The following is a description of a gene set: Mouse Gene Set: REACTOME_G_PROTEIN_ACTIVATION G-protein activation species: Mus musculus, and this is the list of marker genes: Pomc, Gng2, Gng5, Gnb5, Pdyn, Gna14, Gng10, Gng4, Gng13, Gna15, Gnb4, Gngt2, Gnb2, Gng12, Oprm1, Gng11, Gng3, Gng8, Gngt1, Gng7, Gnaq, Gna11, Gnb3, Gnb1